Given this list of marker genes SERPINH1, RARG, MATN1, SMPD3, SOX9, TGFBR2, POC1A, COL27A1, TSKU, here is a description of the gene set: The progression of a chondrocyte over time from after its commitment to its mature state where the chondrocyte will contribute to the shaping of an endochondral bone. studied in species Homo sapiens Human Gene Set: GOBP_CHONDROCYTE_DEVELOPMENT_INVOLVED_IN_ENDOCHONDRAL_BONE_MORPHOGENESIS